The following is a description of a gene set: Genes up-regulated in myeloid dendritic cell 1d vs 0d in adults after exposure to 2011-2012 trivalent inactivated vaccine (A/California/7/09 (H1N1), A/Perth /16/2009 (H3N2), B/Brisbane/60/2008), time point 1D. Comment: Up-regulated DE RNA transcripts (up >= 1.5x) shared between both TIV-vaccinated donors Systems biology is an approach to comprehensively study complex interactions within a biological system. Most published systems vaccinology studies have utilized whole blood or peripheral blood mononuclear cells (PBMC) to monitor the immune response after vaccination. Because human blood is comprised of multiple hematopoietic cell types, the potential for masking responses of under-represented cell populations is increased when analyzing whole blood or PBMC. To investigate the contribution of individual cell types to the immune response after vaccination, we established a rapid and efficient method to purify human T and B cells, natural killer (NK) cells, myeloid dendritic cells (mDC), monocytes, and neutrophils from fresh venous blood. Purified cells were fractionated and processed in a single day. RNA-Seq and quantitative shotgun proteomics were performed to determine expression profiles for each cell type prior to and after inactivated seasonal influenza vaccination. Our results show that transcriptomic and proteomic profiles generated from purified immune cells differ significantly from PBMC. Differential expression analysis for each immune cell type also shows unique transcriptomic and proteomic expression profiles as well as changing biological networks at early time points after vaccination. This cell type-specific information provides a more comprehensive approach to monitor vaccine responses. Human Gene Set: HOEK_MYELOID_DENDRITIC_CELL_2011_2012_TIV_ADULT_1DY_UP from publication Hoek KL, Samir P, Howard LM, Niu X, Prasad N, Galassie A, Liu Q, Allos TM, Floyd KA, Guo Y, Shyr Y, Levy SE, Joyce S, Edwards KM, Link AJ (PMID 25706537) species: Homo sapiens, and this is the list of marker genes: FUNDC1, H2AC20, VCAN-AS1, HDGFL3, EPHB3, MIRLET7BHG, CD163, STAB1, F13A1, CPED1, RNASE2, P2RY12 (purinergic receptor P2Y12), GZMM, CCL3, KIF1C-AS1, NBPF15, PPP1R35-AS1, ID3, CD69, GNAI1, ALOX5AP, RARG (retinoic acid receptor gamma), ZNF253, S100A12, PEDS1-UBE2V1, EMB, FCGR1A, MIR17HG, DEPTOR